The following is a description of a gene set: PTEN Regulation Human Gene Set: REACTOME_PTEN_REGULATION species: Homo sapiens, and this is the list of marker genes: SNAI1, EED, AGO1, PHC2, EZH2 (NCBI Gene Id 392834), CBX4, LAMTOR1, GATAD2B, CBX8 (chromobox 8), RBBP4, PSMD13, UBB, STUB1, PSMC3, USP13, LAMTOR3, CSNK2A1, PSMD2, RHEB, LAMTOR5, GATAD2A, PSMA5, PSMA1, LAMTOR4, SNAI2, TP53, CHD4, SCMH1, CSNK2B, PREX2, TNRC6A, HDAC2, RING1, JUN, PSMD12, TRIM27, AGO2, MLST8, PSMB3, AKT2, HDAC5, HDAC3, PSMA4, HDAC7, PSMA3, MECOM, RRAGB, PTEN, PSMC2, RNF146 (NCBI Gene Id 81847, ring finger protein 146), PSMB7, AGO3, TNKS2, MTA2, PSMD8, PSMB4, PSMB5, LAMTOR2, AGO4, XIAP, PSMD1, MAF1, SEM1, SLC38A9, PSMD11, WWP2, CHD3, OTUD3, CBX6, MAPK3, PPARG, RPTOR, MTA1, PSMB6, PSMC4, PSMA2, CBX2, AKT1, PML, RPS27A, HDAC1, PSMD6, UBA52, RNF2, REST, ADRM1, MKRN1, PSMD7, MTA3, MAPK1, RCOR1, AKT3, ATF2 (activating transcription factor 2), PSMB2, PSMA7, RBBP7, PSMA6, PHC3, MBD3, KDM1A, RRAGA, MOV10, PSMC6, EGR1, MTOR, CSNK2A2, PSMB1, TNRC6C, UBC, BMI1, PSMD14, ATN1, PHC1, PSMD3, NEDD4, RRAGC, TNKS, USP7, SALL4, PSMC5, SUZ12, FRK, NR2E1, TNRC6B (trinucleotide repeat containing adaptor 6B), RRAGD, PSMC1